The following is a description of a gene set: studied in species Homo sapiens An unpleasant sensation characterized by physical discomfort (such as pricking, throbbing, or aching) localized to the knee. Human Gene Set: HP_KNEE_PAIN Knee pain, and this is the list of marker genes: LMX1B, MATN3, HYAL1, B2M, COL9A3, BSCL2, COL9A2, TONSL, COL2A1, GJB6, MMP13, TRAPPC2, COL11A1, COMP, SLCO2A1, GJB2, COL9A1